Given this list of marker genes DUSP18, NDUFV3, SYTL3, PARP12, PLEKHM3, FAM241A, SPOUT1, IL18BP (NCBI Gene Id 10068), CYB561A3, PRKX, ZNF287, ZIC3, SPPL2A, USP18, KCNA3, CMPK2, KHNYN, ATM, CASC3, CSN2, GET1, SHISA5, LEMD1, LTO1 (NCBI Gene Id 72284), THAP2, UBE2L6, RFX2, TRIM25, UBA7, MYO9B, EGFL6, OAS1, TCEANC, TRAF1, MX2, MITD1, ABRA, SAMD9L, ZBTB42, PCGF5, ETNK1, MGME1, GBP4, HOXD10, SETDB2, DZANK1, IFIH1, DDX4, HINFP, UBD, CLIC4, IFIT1B, CCSER1, ATAT1, CCDC18, TAP1, MMP20, TRIM21, DCP2, CH25H, ZC3H7A, IL1R2, RBM5, TTC21B, AKAP10, KCNT2, IFNG (NCBI Gene Id 3458), LRIT2, GZMB, STAT2, SGK3, TRIM5, BATF2, CXCL9 (C-X-C motif chemokine ligand 9), SLC22A15, PPM1K, SLC15A1, ZUP1, ECM2, IFI44, KRBA1, XAF1, CGAS, SLFN13, MTHFD2, JAK2, ANKRD1, SAMHD1, DXO, HERC6, C2orf68, RBM43, ADAR, GPR19, TRIM39, TMEM243, USP27X, ZBP1, TOR1AIP2, CYTH1, KMT5B, SLFN5, GBP6, RTP4, NMI, HELZ2, TNFAIP2, PARP14, AFF3, ITPKA (inositol-trisphosphate 3-kinase A), IQCH, GBP7, METTL4, OAS2, INSL6 (NCBI Gene Id 82352), MVP, HLA-E, NSMCE1, STEAP1, B3GNT5, RNF213, PARP9, USP42, EPC2, ASB13, SLC35D3, SERPINB9, NKG7, PSME2, PML, MTHFR (methylenetetrahydrofolate reductase), PPP1R13B, FPR1, MARCHF5 (membrane associated ring-CH-type finger 5), VWA3B, TMEM117, IRGM, CD40, ZFP69, GTF2IRD2, RPGRIP1, IRF1, RSAD2, TAPBP, IFIT3, PSME1, TRIM56, TNFSF10, SLC25A31, PARP11 (poly(ADP-ribose) polymerase family member 11), BBS1, AGRN, DCK (NCBI Gene Id 1633), FCGR3A, DLX5, ZC3HAV1, PRNP, INPP1, PSMB8, NFATC2IP, ZCCHC2, PSMB10, GBP2 (guanylate binding protein 2), IFIT2, KLRD1, DTX3L, HAO2, CD72, CXCL10, CASP4, RNF114, DAXX, SP110, TLK2, TLR3, RIGI, CXCL11, RRP1B, C2, TUT7 (terminal uridylyl transferase 7), HMGA2, IRF9, TMTC2, ISG15, NLRC5, AREL1, SH2D1A, IFI35, MYH1, PSMB9, TERF2, CD274, RHBDD1, MX1, STX3, TIMELESS, STAT1, BCL11A, DHX58, IFIT1, here is a description of the gene set: Genes up-regulated in HMC-1 (mast leukemia) cells: incubated with the peptide ALL1 versus stimulated with T cell membranes. Human Gene Set: GSE19888_ADENOSINE_A3R_INH_VS_TCELL_MEMBRANES_ACT_MAST_CELL_UP from publication Baram D, Dekel O, Mekori YA, Sagi-Eisenberg R (PMID 20190146) We demonstrate that the G protein Gi3 is the cellular target of the adenosine A3 receptor (A3R). By using a cell permeable peptide comprising the C-terminal end of Gαi3 fused to an importation sequence (ALL1) as a selective inhibitor of Gi3 signaling, we show that by coupling to Gi3, the A3R stimulates multiple signaling pathways in human mast cells, leading to upregulation of cytokines, chemokines and growth factors.Following contact with activated T cell membranes, endogenous adenosine binds to and activates the A3R, resulting in Gi3-mediated signaling. Specifically, the majority of ERK1/2 signaling initiated by contact with activated T cell membranes, is mediated by Gi3, giving rise to ALL1-inhibitable cellular responses. These results unveil the physiological GPCR that couples to Gi3 and establish the important role played by this G-protein in inflammatory conditions that involve adenosine-activated mast cells. We used microarrays to detail the effect of ALL1 on gene expression of HMC-1 cells activated directly by the A3 receptor, or by contact with activated T cell membranes. species: Homo sapiens